The following is a description of a gene set: Human Gene Set: GOBP_MODULATION_BY_HOST_OF_VIRAL_GENOME_REPLICATION species: Homo sapiens A process in which a host organism modulates the frequency, rate or extent of viral genome replication., and this is the list of marker genes: FBXL2, PPIB, TMEM41B, ZFYVE1, PIK3C3, TBC1D20 (NCBI Gene Id 170488), PHB1, ZBED1, SMC6, FMR1, IFI27, DDX56, CCNK, PRKN, EIF2AK4, YTHDC2, NUCKS1, EEF1A1, SMC5, ZC3H12A, VAPB, MIR222, VAPA, MIR221, STOM, CCL8, APOBEC3H